Given this list of marker genes CRYAB, GSR, MPO, THG1L, MIRLET7B, CHCHD2, MAP2K4, PEX13, SCARA3, ROMO1, HAO1 (hydroxyacid oxidase 1, NCBI Gene Id 9999), NOS3, ECT2, PNPLA8, GPX8, FXN, TMEM161A, LRRK2, AAAS, COMT, MAPK13, NAGLU, ATP13A2, UCP3, HM13, TREX1, CCS, PTGS2, SNCA, RHOB, MAPK7, PPEF2, FOXO3, SLC1A1, GPX1, PLEKHA1, CYP1B1, HBA2, ZNF277, FOXP1 (forkhead box P1), PRKCD, HSPA1B, PRKAA2, FOXO4, MBL2, CD2AP, ERCC8, NAPRT, TAT, MMP3, TRPC6, SRXN1, RCAN2, TRIM32, SESN2, SMPD3, CYB5B, FYN, CUL3, IDH1, STX2, SGK2, STK26, HDAC6, AIFM1, ADAM9, TXNIP, STAU1, RBM11, BECN1, BMP7, PCNA, PSMB5, PDK2, PPP5C, XRCC1, CAPN2, PRKD1, ALOX5, COL6A1, HYAL1, TXNRD2, TPO, TRPM2, AMBP, DDR2, UBR4, MT-ND5, MMP2, C19orf12, GPR37L1 (NCBI Gene Id 9283), PAWR, DHFR, HTRA2, MIR132, RAD52, PRDX4, TXN, PML, STAU2 (staufen double-stranded RNA binding protein 2), TOP2B, PRKCA, EZH2, CA3, TRIM25, MAPKAP1, ARL6IP5, DUSP1, BRF2, ATM, MACROH2A1, PTGS1, SRC, MIR34A, FBXO31, SOD2, HMOX1, WNT16, SELENOS, ALDH3B1, STOX1, TMIGD1, FER (NCBI Gene Id 2241), PKD2, ADPRS, NEIL1, MEAK7, OGG1, NFE2L2, PYCR2, ZC3H12A, PEX10, FBLN5 (fibulin 5), RIPK3, CYGB, MDM2, TACR1, GSS, ATF2, PPIA, SP1, SPHK1 (sphingosine kinase 1), UCP1 (NCBI Gene Id 7350), RACK1, CD38, FANCC, GPX4, HBB, PNPT1, LONP1, VRK2, ATP2A2, FCHSD1, DHFRP1, MAPK9, PRR5L, MET, MT-CO1, MTF1, ABCC9, CRYAA, MIR133A1, PEX12, MIR17, MB, PRKAA1, BTK, GCLC, IL6 (interleukin 6), PEX5, NME8, MAPK8, UCN, GPX5, KCNA5, FADS2, NR4A2, RBX1, ERCC2, DCAF11, CDKN2A, APOA4, GCLM, ADCYAP1R1, NPPA, PRKN, ZNF580, AKT1, STAT1, APOD, SETX, USP25, RIPK1, FGF8, MSRA, ETFDH, ERCC1, PCGF2, PRDX6, PXN, HP, SIRT1, FABP1, COL1A1, RNF112, XPA, XBP1, MAP2K1, ARNT, IL18RAP, PARP1, MT-ND3, NUDT15, STC2, HBA1, GPX7, IPCEF1, ADIPOQ, SELENOK, PRNP (prion protein (Kanno blood group), NCBI Gene Id 96713), ERCC3, SLC25A14, TLDC2, MSRB3, ZFAND1, GGT7, AGAP3, DUOX2, JAK2, MMP14, ABCD1, BAK1, KAT2B, PYCR1, KEAP1, MIR92A1, MAP1LC3A (NCBI Gene Id 84557), BCL2, TNFAIP3, IL18BP, APOE, DHRS2, HSPA1A, CRYGD, HYAL2, TPM1, PLA2R1, EDN1, RPS3, PARK7, ERO1A, ATE1, OXSR1, CD36, SELENON, MPV17, ANKZF1, MGST1, SOD3, SESN1, PRDX3, CRK, ERCC6L2, G6PD, MT3, S100A7, GPX2 (NCBI Gene Id 2877), MCTP1, DAPK1, ALS2, RELA, PXDNL, LCN2, ABCC1, SESN3, TET1, MICB, BMAL1, KLF4, HGF, MAP3K5, PEX14, FUT8 (fucosyltransferase 8), NUDT2, ABL1, STK25, PPARGC1A, AREG, MIR135A1, PINK1, CHUK, TRAP1, RCAN1, UCP2, STX4, GATA5, PENK, ETV5, COA8, NUDT1, AIF1, NR4A3, ATP7A, PSEN1 (NCBI Gene Id 5663), GPX6, SIRPA, ABL2, RWDD1, PNKP, PTPRN, ERCC6, ANGPTL7, SOD1, PTPRK, TP53INP1, NQO1, ERN1, SUMO4, BANF1, TRPA1, VKORC1L1, ATF4, SLC8A1, CAMKK2, CFL1, OXR1, GSTP1, NFE2L1, EDNRA, OSER1, PRDX1, WRN, KRT1, PSIP1, SLC11A2, EPAS1, SELENOP, CASP3, CHRNA4, LIAS, PPP2CB, PRKRA, PPIF, CBX8, MIR21, HMOX2, RLIG1, RGS14, PDLIM1, ALAD, MSRB2, FOXO1, DGKK, PRDX2, NET1, EIF2S1, HIF1A, PDCD10, HSF1, ENDOG, EPX, PRDX5, SLC23A2, PXDN, AIFM2, NCOA7, KPNA4, PDGFRA, ERMP1, PJVK, RBPMS, LPO, MGAT3, MAPT, SLC25A24, GPR37, AQP1, SIRT2, TOR1A, PYROXD1, KLF2, GPX3, VNN1, TBC1D24, CDK1, PDGFD, BNIP3, SLC7A11, MT-ND1, CAT, FANCD2, PPP1R15B, PEX2, SCGB1A1, ATOX1, BTG1, MYB, SLC4A11, RRM2B, KCMF1, GCH1, MIR103A1, TP53, SIN3A, KDM6B, STK24, EEF2, FOS, HDAC2, PLK3, MIR107, DUOX1 (dual oxidase 1), here is a description of the gene set: Any process that results in a change in state or activity of a cell or an organism (in terms of movement, secretion, enzyme production, gene expression, etc.) as a result of oxidative stress, a state often resulting from exposure to high levels of reactive oxygen species, e.g. superoxide anions, hydrogen peroxide (H2O2), and hydroxyl radicals. Human Gene Set: GOBP_RESPONSE_TO_OXIDATIVE_STRESS species: Homo sapiens